Given this list of marker genes NUP214, CCN2, MT-CO2, FAS, GATA2, PERCC1, DLL1, AIMP1 (aminoacyl tRNA synthetase complex interacting multifunctional protein 1), ZIC2, CAV1, COQ2, TGFBR2, BAZ1B, NDUFV1, CLMP (NCBI Gene Id 79827), SUCLG1, NDUFS2, KRAS, STAT3, SSR4, LPL, AASS, NSD1 (nuclear receptor binding SET domain protein 1), NDUFS1, SUFU, RET (ret proto-oncogene), NRTN, MALT1, ACAT1, CPT2, MC2R, LIG3, CDKN2B, PALB2, RNF6, FH, STIL, RFC2, MGME1, SCNN1G, HLCS, ADNP, TXNRD2, LIPA, SLC46A1, MPV17 (NCBI Gene Id 4358), COL1A1, MYLK, TMEM127, PDCD10, SLC22A5, EXT2, PYCR2, PHKB, KLRC4, ATP6V0A4, GMPPA, ATRX, POLD1, TRAF7, LMOD1, IRAK1, MLH1, MT-ND1, ANO1, CHEK2, OPLAH, BSND, ACADVL, CARD8 (NCBI Gene Id 22900), TBK1, NDUFAF3, PNPT1, MEFV, HLA-B, DISP1, SCN5A, ST3GAL5, RHBDF2, SLC25A4, BUD23, LRRK2, COL4A6, POGZ, NLRP3, GFM2, PTEN, GAMT, SCNN1A, METTL27 (methyltransferase like 27), RANBP2, IFNGR1, SMO, CLCNKA, ACAD8, NLRC4, SDHA, HNF4A, MUTYH, ASL, DLD, IL10, FOXP3, CPOX, SMC1A, FOXP1 (NCBI Gene Id 87246), ALDOB, ATP1A2, PRDX1, ALPL, TWNK, ACTG2, LBX1, ANAPC1, MT-TV, MSH2, ARG1, TIMMDC1, NDUFA11, MYH11, FAH, ABCD1, CDKN1A, TNFRSF1A, NDUFA1, CYP11A1, TMEM270, PARK7, HNRNPK, KIF21A, IL18BP, DOLK, HLA-DRB1, IVD, TNF, AVP, HPRT1, GK, MSH6 (NCBI Gene Id 2956), BCL10 (BCL10 immune signaling adaptor), SDHB, GTF2IRD1, KYNU, NOTCH2NLC, MT-TQ, NDUFB8, KCNQ2, AIP, FBXO11, GHSR, ERBB3, NPPA, NAXD, HS3ST6, PCCA (NCBI Gene Id 5095), IRF5 (NCBI Gene Id 84729), TRAPPC11, PMS1, NCF1, CCR6, PHKA2, F12, SLC25A15, HMGCS2, SCN2A, MEN1, SCNN1B, FOXRED1, SAA1, CCM2, TRMT5, KCNJ5, NODAL, NEUROG3, GDNF, SLC19A3, STAR, FOXH1, C4A (complement C4A (Chido/Rodgers blood group)), NNT (NCBI Gene Id 23530), ALDH18A1, WWOX, UCHL1, TUBB2B, PHKG2, ITGA6, SLC2A9, RARS1, ACADM, EPAS1, STX1A, SLC25A13, ACY1, BRCA2, SIX3, FGF8, CUBN, SUOX (sulfite oxidase), AMN, STK11, ACSL5, TMEM126B, PMM2, NDUFAF4, RECQL4, POLG, MVK, EGFR, MT-CYB, NDUFA2, ALG11, EDNRB, TYMP, MTRR, FSHR, EDN3, GALE, DNAJC6 (DnaJ heat shock protein family (Hsp40) member C6), GTF2IRD2, CYP11B2, FBLN5, UBAC2, SMARCB1, LRPPRC, RAB27A, MMUT, CLCN2, PLEC, CLDN16, ALG9, UNC45A, RRM2B, ATM, DGUOK, MMAA, EPCAM, SAT1, NAGS, RRM1, MRAP, SYT1 (NCBI Gene Id 6857), PHOX2A, ELP1, EDNRA, GBA1, SI, HADH, RYR1, CLCNKB, MET, COA8, UQCRC2, MT-TK, MT-TL1, SLC37A4, SPTBN1, GALC, GRB10, SLC25A11, NEXMIF, NDUFS6, TUBB3, EIF4H, ZEB2, PCCB, PTPN22, EWSR1, NDUFS3, DNASE1L3, LAMC2, CFI, PRKN, TGIF1, FBXL4, PDGFRA, AQP2, NF2, SPINK1, COL25A1, TRMU (tRNA mitochondrial 2-thiouridylase), LIG4, LAMA3, NDUFAF1, TOM1, SREBF1, GFAP, ATP7B, PPOX, POLE, MT-ND2, HLA-DQA1, ECE1, HMBS (hydroxymethylbilane synthase), DGAT1, CRIPTO, VPS37D, NDUFB3, ASXL3, NDUFS8, BAP1, GLA, NDUFA6, CDK13, CPS1, STAT4, PDGFB, DLST, FLNA, CYP11B1, CYC1, MAX, NDUFS4, CYP24A1, CTNNB1, TERT, PSAP, CTLA4, GAS1, TET2, KIT, NAA10 (NCBI Gene Id 8260), APC (APC regulator of WNT signaling pathway), CCR1, COL5A1, GTF2I, PAH, SDHC, TICAM1, PGM1, BRAF, D2HGDH, BIRC3, KRIT1, KCNJ11, COL4A5, TLR4, BCKDHA, LIMK1, MPI, CD55, KCNJ1, ETFDH, CDC73, ATP9A, PMS2, TP53, MTTP, HLA-DPA1, CDON, FBP1, ASS1, BRCA1, ZFX, CA5A, MT-TS2, YARS1, KIF1B, DHCR7, PIGY, MT-ND6, KIAA0319L, MT-TC, CACNA1A, NDUFB10, ELN, AVPR2, FKBP6, UQCC2, COL5A2, ACSF3, HSD3B2, NDUFS7, UFC1 (NCBI Gene Id 51506), HLA-DQB1, MT-CO1, ETFA, SEMA3D, MT-TH, PKHD1, SMPD1, VPS13C, ASPA, SDHAF2, NDUFB9, MTHFD1, ERBB2, NDUFAF2, HTRA2, CD46, ATP7A, ESR1, MT-ND4, ATP1A3 (ATPase Na+/K+ transporting subunit alpha 3), NSUN2, STX3, BTD, CFH, CDKN1B, LAMB3 (NCBI Gene Id 3914), TIMM22, PRTN3, FLI1, SMAD4 (NCBI Gene Id 4089), ERAP1, RPS20 (NCBI Gene Id 6224), SHANK3, PTCH1, NDUFV2, CDC42BPB, SLC22A12, HIKESHI, PALLD, SUGCT, AAAS, ENPP1, FOCAD, CACNA1D, TLR3, SERPING1, HELLPAR, MED12, MMAB, ASXL1, GALT, MT-ATP6, CDKN2A, FARSB, PLCH1, TRANK1, MRPS7, SLC5A6 (solute carrier family 5 member 6), CLIP2, NF1, RNH1, ALG3, ABCC8, AGR2, SEMA3C (NCBI Gene Id 222200), HLA-DPB1, NBAS, GAN, NR3C2, ALX4, IL23R, CTNS, MT-ND3, BMPR1A, TBL2, PHGDH, CDH23, DYRK1A, SLC6A8, MYC, UQCRH, TUBA1A, KCNA1, SLC12A1, SLC12A3, SYK, NR0B1 (nuclear receptor subfamily 0 group B member 1), FGF13, SEMA4A, GLI2, SYNJ1, GPD1, SAR1B, OXCT1, PPM1D, MT-TW, MT-TF, SLC1A3, MRPL39, BOLA3, NDUFB11, IKZF1 (IKAROS family zinc finger 1), DNAJC30, RABL3 (NCBI Gene Id 285282), SLC5A1, NDUFAF5, SRSF2, CDKN2C, VHL, CTRC, SNCA, PODXL, MTR, ITGB4, TRAF3, SEC61A1, MDH2, MMACHC, HMGCL, STAG2, MCCC1, ALG8, DBH, WT1, PINK1, SPP1, ABCC6, TREH, SHH, DLEC1, TEFM, MLYCD, SDHD, AKT1, NDUFAF8, UNC93B1, ALAD, TCN2, ZFTA, OTC, KMT2E, IL12A, MARS1, MT-CO3 (mitochondrially encoded cytochrome c oxidase III), MCCC2, DNMT3A, NUBPL, MT-ND5, FGFR1, PIK3CA, CDK8, MSX2, NARS2, HIBCH, KARS1, NFIX, SMARCE1, IL12A-AS1, TTR, SLC7A7, ETFB, here is a description of the gene set: Nausea and vomiting Nausea is a commonly encountered symptom that has been defined as an unpleasant painless subjective feeling that one will imminently vomit. Vomiting has been defined as the forceful expulsion of the contents of the stomach, duodenum, or jejunum through the oral cavity. While nausea and vomiting are often thought to exist on a temporal continuum, this is not always the case. There are situations when severe nausea may be present without emesis and less frequently, when emesis may be present without preceding nausea. studied in species Homo sapiens Human Gene Set: HP_NAUSEA_AND_VOMITING